The following is a description of a gene set: Category D genes: p53-independent genes whose expression in the absence of S389 phosphorylation is similar to loss of TP53 in MEF (embryonic fibroblast) cells in response to UV-C irradiation. Mouse Gene Set: BRUINS_UVC_RESPONSE_VIA_TP53_GROUP_D species: Mus musculus from publication Bruins W, Bruning O, Jonker MJ, Zwart E, van der Hoeven TV, Pennings JL, Rauwerda H, de Vries A, Breit TM (PMID 18195040) Phosphorylation is important in p53-mediated DNA damage responses. After UV irradiation, p53 is phosphorylated specifically at murine residue Ser389. Phosphorylation mutant p53.S389A cells and mice show reduced apoptosis and compromised tumor suppression after UV irradiation. We investigated the underlying cellular processes by time-series analysis of UV-induced gene expression responses in wild-type, p53.S389A, and p53(-/-) mouse embryonic fibroblasts. The absence of p53.S389 phosphorylation already causes small endogenous gene expression changes for 2,253, mostly p53-dependent, genes. These genes showed basal gene expression levels intermediate to the wild type and p53(-/-), possibly to readjust the p53 network. Overall, the p53.S389A mutation lifts p53-dependent gene repression to a level similar to that of p53(-/-) but has lesser effect on p53-dependently induced genes. In the wild type, the response of genes to UV irradiation was strictly biphasic. The early stress response, from 0 to 3 h, results in the activation of processes to prevent the accumulation of DNA damage in cells, whereas the late response, from 12 to 24 h, relates more to reentering the cell cycle. Although the p53.S389A UV gene response was only subtly changed, many cellular processes were significantly affected. The early response was affected the most, and many cellular processes were phase-specifically lost, gained, or altered, e.g., induction of apoptosis, cell division, and DNA repair, respectively. Altogether, p53.S389 phosphorylation seems essential for many p53 target genes and p53-dependent processes., and this is the list of marker genes: Tcam1, Cflar, Plvap, Stt3a, Zc3h13, Cbln2, Etv4, Ptk2, 2610005L07Rik, Lat2, Sema3a, Il2ra, Dnm1l, 1810013D15Rik, 2510002D24Rik, Hook1, Lmntd1, Sh3bgr, Mbp, Tbx20, Phactr1, D530037P16Rik, Ccdc57, 1700020D12Rik, Nr1d2, Amigo1, Ube2o, Gsk3b, Slc20a2, 4930455G09Rik, Klhl42, Hk1, Fpr-rs3, Tmem176a, Chrng, Ube2ql1, Dnajc10, Ipo4, Gtpbp4, Slc30a1, Fbxw11, Cck, Tekt5, Trak1, Hemgn, Ppp1cb, Aldh1b1, Extl2, B3galnt1, Prl8a9, Ccl2, Atp1b2, Tada3, Rnu5g (NCBI Gene Id 97418), 4930480K02Rik, Cnfn, 9630009A06Rik, Tpi1, Chrna6, Xlr4c, Trim59, Phka2, Kdm5d, Trip10, Fbxo32, Zbtb22, Diaph2, Azin1 (antizyme inhibitor 1), Exosc6 (exosome component 6), Rnf121, Fam151b, Bmi1, 4930512B01Rik, Fmod, Lama5, Crmp1, 2900092C05Rik (RIKEN cDNA 2900092C05 gene), Slc9a2, Spopl, Cyp1a2, Pxdn, Capza1b, Rab15, Fndc8, Krt2, Spata9, Fmo2, Vps50, Mia, Zranb2, Ears2, Tdgf1-ps2, 0610005C13Rik, Slit2, Pitpnc1, B3galt1, Tescl, Rnf138, Apof, Tmem170, Hdhd5, Aqp11, Ark2c, Etos1, Tunar, Slc17a9, Oca2, Spag5, Vdac1, Hspb7, Ttyh1, Cypt1, Enpp3, Arhgef10l, Cpe, Gsdmd, Macrod1, Slc32a1, 1700028E11Rik, Stbd1, Slc22a23, Prl, Sln, 9630015K15Rik, Cacul1, Bloc1s1, Nopchap1, Spmap2, Rhd, Nrarp, Inafm1, 1700023F02Rik, Gapdh, Slc12a9, Prdm4, 6530401F13Rik, Exoc6b, Lrrc15, 4933407L21Rik, Serpina1b, Ncbp3 (nuclear cap binding subunit 3), Card11, Ndor1, Tbc1d22bos, Tmcc2, A030001D20Rik, 4933416I08Rik, Plod3, Appl2, Adgra2, Cys1, Rbm34, Rbm25, 9530020I12Rik, Chil3, 5031434O11Rik, Pdpn, C030006K11Rik (NCBI Gene Id 78691), Phkg1, Tcp1-ps1, 1700014L14Rik, Mid1ip1, Uba5, 3110043J17Rik, Phgdh, Tiprl, Usp32, Uxs1, Snx9, Cbx6, Rab3d (NCBI Gene Id 83761), 1700063H04Rik, Phka1, Itpr2, Tnfrsf4, Zdhhc3, Dmd, Plcb2, Ces2f, Dusp10, Tnfsf13b, Snhg17, Myog, Fcho1 (FCH domain only 1), Bcl2a1a, Morn1, Adissp, Parn, Nefm, 4933416O17Rik, Gabra5, Boc (BOC cell adhesion associated, oncogene regulated), Ccser2, Cd48, Cfap126, 9430087B13Rik, Ccl7, Lgr5, Grk2, Aldh5a1, Gjb3, Scaper, Rbm20, Fads1, Calcrl, Ctps1, Luc7l2, Flacc1, Cyfip2, Vmn2r-ps54, Kcna3, Sdr39u1 (short chain dehydrogenase/reductase family 39U, member 1), Lgals3, Dennd1b, Arih1, Adm, Kera, Arrdc2, Cd79b, Pax5, H2-K2, Mup3, Zfp14, Arhgap45, Erv3, Smim23, Mzt1, Lbx1, Gsta4, Tgfbr3, Sphkap (SPHK1 interactor, AKAP domain containing), Fam107b, Cd2, 4930593A02Rik, Pgm2, Copb1, Tmem35a, Gadd45b (growth arrest and DNA-damage-inducible 45 beta), Abcb11, Ddx21, 2610028E06Rik, Myo1a, Cited4, Olfml2b, Srebf2 (NCBI Gene Id 20788), ENSMUSG00000123778, Snapc1, Socs6, Srcin1, Lrrc8e, Dbil5, Zfp92, Dusp23, Sh3pxd2a, Vegfc, Prune2, ENSMUSG00000124774, Fhad1, Spen, Akr1c6, Clxn, Ppp1r12b, Rnf122, Hhatl, Kcnma1, Sag, Onecut1, Septin3, Osbpl3, Prkg2, Osmr, Txnrd3, Zbtb8a, C030037D09Rik, Sgcb, Ctsj, Plekha3, 1700037C18Rik, Kdelr2, Mall, Rara, Slc52a2, Ddx3x, Atp6ap2, Gdf10, Izumo3, 1700029B24Rik, Bid, Cpa1, 9530078K11Rik (NCBI Gene Id 78564), Zfp26, Polr3g, Trem3, Efcab15, Snora64, Blk, 4930417O22Rik, B230206I08Rik, Gnat1, Cabp1, Kif16b, Pdcd1lg2, Trdn, Tsc22d2, Ggta1, Pus3, A930015D03Rik, Fcgr2b (NCBI Gene Id 98391), Trmt13, Tiam1, Mfsd6, 4930442J19Rik, Enho, Ltbp1, Runx3, Nr2e3, 1700030A11Rik, Prpf3, Synpo2l, Pitx3, Bicdl1, Efna2, Krt84, 1810019D21Rik, Ago2, Crygc, 4921534H16Rik, Csmd3, Kif26b, Nktr, Adipoq, Rhbg, Atcayos, 4930486L24Rik, Scgb3a1